Given this list of marker genes TRABD2B, PPP3R1, TP53I11, FLNA, HADHA, CCDC28A, LRP1, DES, UBR5, ZMIZ2, CRTC1, TMEM104 (transmembrane protein 104), SARM1, TMCC2, RXRA, AK1, ZBTB2, GUCA1B, CEP85, CORO1C, JADE2, SLC43A2, WWP1, MFNG, ZFP41, FAM53B, GLIS2, GRIK3, LAYN, IL17REL, ARID3B, SLC7A1, ZNF600, NNAT, TEAD2, NOVA2, SPSB4, HSPB6, SHISA6, CRHR2, MTCL2, UBR2, GARRE1, CCL28 (NCBI Gene Id 56477), CPNE5, KCNE4, STAMBP, GGT7, ZNF395, SH3PXD2A, FOXN3, KIF21B, PPP1R7 (protein phosphatase 1 regulatory subunit 7), SLC38A1, CELF3, KCNT1, SH3KBP1, HMGA1, SEMA3G, AKAP4, P2RX1, DHCR24, PELATON, RHOQ, NFIC, NAT8L, CBX6, SLC30A7, ZNF219, PLXNA2, ADGRL1, ACTMAP, FAM219A, PPME1, ENSA, HECTD1 (HECT domain E3 ubiquitin protein ligase 1), TNFRSF10C, PLEC, OSBP2, PLXNA4 (NCBI Gene Id 91584), SYNGAP1, DAOA, ASCC2, SLCO2B1, PIP4K2B, ASIC1, SH3GL1, NCS1, PDGFB, AFF3, SMAD3, B3GNTL1, CBFA2T3, PROX1, RCAN2, NCLN, SPEG, TTBK1, RBMS2, CLCC1 (chloride channel CLIC like 1), POU2F2, B3GAT1, ORAI2, MLPH, PTAR1, SYT1, AAK1, CSK, LYSMD1, PIANP (PILR alpha associated neural protein), DHX8, ST6GALNAC6, NDST1, SLC7A8, MNT, NEURL1, CMTM3, VPS37C, CHRM1, CIMIP2B, CASS4, ARHGDIA, SDK2, DPYSL5, ENG, ST8SIA5, PPP1R3B, ESPN, GIPC3, MOB3C, TPCN1, DMWD, PPP1R16B, SMARCD2, VSX2, KSR2, NFX1, SMIM7, ARMC6, CPTP, AGAP2, SP1, ANKS1A, PHACTR4, SCUBE3, MARCHF8, TMEM184A, CEACAM6, ADAP1, SLC25A22, CACNA1E, RASGEF1A, BBC3, GPC1, CCDC157, CORO1A (NCBI Gene Id 11151), STK40, FSCN1, DNMT3A, GRAMD1B, SHROOM4, TUBB4B, ARHGAP35, PAX5, BARHL1, PLXDC2, CLVS1, ABCG4, PPFIA2, ZDHHC22, RERE, TENM1, SMYD1, WDFY1, DENND1A, FMNL3, NECTIN1, SULF2, TANC2, SELENON, TRARG1, RIMS4, RALY, AMACR, RNLS, PSAPL1, PACS1, ABR, ARNT, LMX1B, NFIB, HCN4, EMILIN3, WDTC1, C7 (NCBI Gene Id 636878), NF2 (NF2, moesin-ezrin-radixin like (MERLIN) tumor suppressor), ECE1, CIRBP, SNX29, ADCY1, DUSP8, SCD5, TBC1D16, PPIP5K1, PXN, MLKL, NFIX, RAB43, UCP2, SLC35E1, NAPA, MED26, SUV39H1, GATAD2A, EME1, NATD1, ADCY6, DMBX1, RPGRIP1L, SEPTIN3, CD28, RING1, IGF2BP1, IGFBP5, SMPD3, SEZ6 (seizure related 6 homolog), ATF7, TSBP1, PTDSS2, TBC1D13 (TBC1 domain family member 13), CPLX2, TMEM63C, SHISA7, PLEKHO1, PARP16, MAPKAP1 (NCBI Gene Id 79182), ZDHHC14, ADRB3, BMP8B, PSG1, NPLOC4, FBXO41 (NCBI Gene Id 150727), MEIS2, MYO1D, SHB, RAPGEF5, CLOCK, RSPRY1, SIX3, here is a description of the gene set: from publication Chen Y, Wang X (PMID 31504780) Genes predicted to be targets of miRBase v22 microRNA hsa-miR-5787 in miRDB v6.0 with MirTarget v4 prediction scores > 80 (high confidence targets). studied in species Homo sapiens Human Gene Set: MIR5787